Given this list of marker genes NAB2, BMAL1, PSD4, CKLF, KLHDC2, TEX264, PNPLA7, MERTK, MFSD5, EEF1AKMT1, FXYD5, PPP1R17, STX6, TMCC3, CDIP1, INPP4A, NTRK3, TNFRSF1B, NDRG3, TBPL1, PHTF1, SELENOS, ARHGAP30 (Rho GTPase activating protein 30), TRMT1L, ABTB3, AFP, TEN1, ZNF707 (NCBI Gene Id 286075), CSRNP2, TLK1, RNF167, SAT1, TMEM127, ZNF790, PRMT2, FAAH, USP18, TOMM70, GTF2H1, TCOF1, NLRC3, TBXA2R, STAT4, IFIT3, MAN2B1, VAPA, RAF1, GTF2H2, HMGCR, EPM2AIP1, NAE1, ANTKMT, AAMP, SDHAF1, RAB3GAP1, CD3E, PATL1, SPATA2, HIGD2A, RRAS2, PIGO, MRS2, KLC1, DGAT1, DENND11, ORMDL1, FAM50A, MRPL22, NUP43, PHF5A, MTSS1, CSNK1G2, MARCO, CSNK1G1, NXF1, ARHGEF4, IFFO2, AEBP2, EIF2AK3, PSME1, CREBL2, ABHD17A, FDFT1, TASOR, PDZD8, GPATCH8, PHF23, EIF2B4, TRADD, MLH3, OCIAD1, ATP1B1, TTC14, RABIF, ATP6V1H, TMEM128, MAVS, TNFRSF18, TNRC6C, ST8SIA6, FOXN3, CNP, TMEM258, ANKRD39, CHMP1A, NSMCE3, AIRN, TEX10, BCLAF1, KLHL28, FRS2, DLGAP4, DYNLRB1, PPCS, ZNF142, XDH, ADAM17 (NCBI Gene Id 6868), MRPL24, NLK, AVEN, MACIR, TMEM199, SH2D3C, MINDY3, NFKBIE, ARFIP1, ARF6, NRBF2, SIKE1 (suppressor of IKBKE 1), NCK1, CBR1, INPP5F, DDI2, SPP1, SNHG3, PPP1CA, SZT2, FNBP1, RHOH, ABHD12, PEDS1, EEF1G, CD37, RAP2B, ABCB1, MCUB, TNKS2, WSB2, PICALM, AR, STMP1 (short transmembrane mitochondrial protein 1), RNF114, IMP4 (NCBI Gene Id 92856), MVB12A, CNN2, MIEN1, CXorf38, RPL18A, ECEL1, YIF1A, IL27RA, TP53BP2, LRP10, CDR2, ZNF672, ZFP82, EZH1, FBXL12, SLFN13, RGS5, NCOA6, LIMK2, MRPL32, CD38, TOX4, KLK8, CCPG1, GAK, RCSD1, THADA, RIGI, PLTP, SACS, SEC11A, PYCARD (PYD and CARD domain containing), LETM1, BANK1, KXD1 (KxDL motif containing 1), RHOG, PGAP1, BDH1, IL21R, MAP3K5, DEGS1, GOSR1, SLC9A9, CAB39, ACCSL, MZB1, MKLN1, here is a description of the gene set: from publication Kim TD, Terwey TH, Zakrzewski JL, Suh D, Kochman AA, Chen ME, King CG, Borsotti C, Grubin J, Smith OM, Heller G, Liu C, Murphy GF, Alpdogan O, van den Brink MR (PMID 18178870) Human Gene Set: GSE5503_LIVER_DC_VS_MLN_DC_ACTIVATED_ALLOGENIC_TCELL_DN Transcriptional response of murine allogeneic T cells (B10.BR) after stimulation with different organ-derived (spleen, liver, peripheral and mesenteric lymph nodes) dendritic cells (C57BL/6) in vitro species: Homo sapiens Genes down-regulated in allogeneic T cells after stimulation with dendritic cells from: liver versus mesenteric lymph nodes (mLN).